Given this list of marker genes EPB42, MAEA, HDAC6, G6PD, L3MBTL3, HEATR3, ZBTB7A, RHEX, NEMP1, BRD1, BAP1, RAC2, FLVCR1, PTBP3, FAM210B, RAC1, EPO, HBZ, DIAPH3, TAL1 (NCBI Gene Id 6886), ERCC2, PLA2G10, TRIM58, KLF2, here is a description of the gene set: A developmental process, independent of morphogenetic (shape) change, that is required for an erythrocyte to attain its fully functional state. Human Gene Set: GOBP_ERYTHROCYTE_MATURATION studied in species Homo sapiens